The following is a description of a gene set: Any process that results in a change in state or activity of a cell or an organism (in terms of movement, secretion, enzyme production, gene expression, etc.) as a result of a vitamin A stimulus. Human Gene Set: GOBP_RESPONSE_TO_VITAMIN_A species: Homo sapiens, and this is the list of marker genes: ABCB1, ALDH1A2, LRAT, MAP1B, CYP26A1, EPO, PPARD, CYP26B1, RARA, DNMT3A, SLC34A1, CAT, LIPA, GATA4, CYP1A1